The following is a description of a gene set: species: Mus musculus Mouse Gene Set: GOBP_NUCLEOSIDE_DIPHOSPHATE_METABOLIC_PROCESS The chemical reactions and pathways involving a nucleoside diphosphate, a compound consisting of a nucleobase linked to a deoxyribose or ribose sugar esterified with diphosphate on the sugar., and this is the list of marker genes: Pkm, Gapdhrt2, Hif1a, Ak2, Myc (myelocytomatosis oncogene), Khk, Eno1b, Zbtb20, Guk1, Prkaa1, Gpd1, Actn3, Bad, Mlx, P2rx7, Pfkl, Nupr1, Entpd4, Entpd7, Insr, Entpd2, Pgam1, Pgam2, Aldoc (aldolase C, fructose-bisphosphate), Mpi, Hk2, Eno1, Aldob, Nudt5, Myog, Ak9, Pals2, Trim63, Gapdhrt, Psen1, Prkag3, Zbtb7a, Pfkp, Ppara, Sirt6, Gpi1, Dhtkd1, Pgk1, Il3, Pfkm, Entpd1, Pfkfb3, Dhodh, Ogdh, Ppp2ca, Bpgm, Rrm2b, Eno2, Hk3, App, Adpgk, Dtymk, Fbp1 (fructose bisphosphatase 1), Entpd4b, Prkaa2, Tpi1, Galk1, Ak4, Prkag2, Lipa, Eno3, Sik2, Ddit4, Entpd8, Slc29a1, Ncor1, Tigar, Foxk1, Pfkfb2, Aldoart1, Mtor, Rptor, Arl2, Git1, Ak3, Gapdhs, Gapdh (glyceraldehyde-3-phosphate dehydrogenase), Eif6, Prxl2c, Ins1 (NCBI Gene Id 16333), Jmjd8, Enpp1, Gale, Aldoa, Mtch2, Igf1, Kat2b, Src, Cbfa2t3, Mlst8, Ins2, Cad, Pals1, Ifng, Nt5e, Ier3 (NCBI Gene Id 15937), Htr2a, Ampd3, Entpd5, Pfkfb1, Rrm1, Mfsd8, Arnt, Ppargc1a, Esrrb, Galt, Cmpk2, Trex1 (three prime repair exonuclease 1), Col6a1, Ogt, Stat3 (signal transducer and activator of transcription 3), Fkrp, Eno4, Hdac4, Ep300, Nudt18, Cant1 (NCBI Gene Id 76025), Slc4a1, Prkag1, Aldoart2, Umps, Nudt7, Prkaca, Ucp2, Foxk2, Gck (glucokinase), Slc2a6, Ak1, Entpd3, Pgk2, Tkfc, Hk1, Rrm2 (NCBI Gene Id 217442), Bcl2l13, Hkdc1, Nudt9, Cmpk1, Flcn, Slc4a4, Pklr, Uchl1 (NCBI Gene Id 97283, ubiquitin carboxy-terminal hydrolase L1), Mlxipl (NCBI Gene Id 58805)